Given this list of marker genes BTBD10, RICTOR, SLC25A3, AFF3, CASR, CADM1, FAM171A1, SLC30A4, EVL, COQ10A, GNB4, AICDA, KRAS, LDHA, CD163, PHYHIPL, TRIM13, MYCBP2, ADGRB3, NRXN1, RLBP1, RNF220, TSR1, NIPAL3, MCPH1, HOXD3 (homeobox D3), IL7R, FOXO3, GLP2R, WDR82, SNX31, OLA1, SCAF4, ITGA6, ASXL3, RBM24, UCK1, FAM216B, ABHD5, SPDL1, COL5A1, ADAR, CD55, JTB, OTULINL, EIF4E (NCBI Gene Id 1977), C5orf24, SH2D1A (NCBI Gene Id 4068), SCN1A, GOSR1, ANKRD40, SYNCRIP, SCN3A, ARMCX3, DR1, BCL2L14, KRT82, SYT4, EIF5B, COPRS, CHST3, TMEM243, NOM1, LHX6, RWDD2A, SEC61A2, CCDC68, SDC3, DMXL1, AEBP2, FGFR1, MYH10, PTPRG, OXR1, INO80D, CCDC181, SORBS2, TMPRSS2, SLC10A7, UBE2QL1, KIF3B, OASL, UGCG, EID1, R3HDM2, TRDN, MIB1, PDCD4, DNAJC27, HGF, DNAJC13, MTUS2, IL5RA, ILF3, EPB41L2, SLC19A3, GPR180, PPP2R2A, BCCIP, MBLAC2, GDA, here is a description of the gene set: Human Gene Set: MIR6760_3P from publication Chen Y, Wang X (PMID 31504780) Genes predicted to be targets of miRBase v22 microRNA hsa-miR-6760-3p in miRDB v6.0 with MirTarget v4 prediction scores > 80 (high confidence targets). studied in species Homo sapiens